The following is a description of a gene set: Human Gene Set: FLETCHER_PBMC_BCG_10W_INFANT_PPD_STIMULATED_VS_UNSTIMULATED_10W_DN species: Homo sapiens Genes down-regulated in peripheral blood mononuclear cell stimulated vs unstimulated in infants (10w) after exposure to BCG (Danish strain BCG Statens Serum Institut, Denmark), time point 10W. Comment: PBMCs drawn at 10 weeks following immunization at birth from publication Fletcher HA, Keyser A, Bowmaker M, Sayles PC, Kaplan G, Hussey G, Hill AV, Hanekom WA (PMID 19239680) BACKGROUND: Novel tuberculosis (TB) vaccines recently tested in humans have been designed to boost immunity induced by the current vaccine, Mycobacterium bovis Bacille Calmette-Guerin (BCG). Because BCG vaccination is used extensively in infants, this population group is likely to be the first in which efficacy trials of new vaccines will be conducted. However, our understanding of the complexity of immunity to BCG in infants is inadequate, making interpretation of vaccine-induced immune responses difficult. METHODS: To better understand BCG-induced immunity, we performed gene expression profiling in five 10-week old infants routinely vaccinated with BCG at birth. RNA was extracted from 12 hour BCG-stimulated or purified protein derivative of tuberculin (PPD)-stimulated PBMC, isolated from neonatal blood collected 10 weeks after vaccination. RNA was hybridised to the Sentrix(R) HumanRef-8 Expression BeadChip (Illumina) to measure expression of > genes. RESULTS: We found that ex vivo stimulation of PBMC with PPD and BCG induced largely similar gene expression profiles, except that BCG induced greater macrophage activation. The peroxisome proliferator-activated receptor (PPAR) signaling pathway, including PPAR-gamma, involved in activation of the alternative, anti-inflammatory macrophage response was down-regulated following stimulation with both antigens. In contrast, up-regulation of genes associated with the classic, pro-inflammatory macrophage response was noted. Further analysis revealed a decrease in the expression of cell adhesion molecules (CAMs), including integrin alpha M (ITGAM), which is known to be important for entry of mycobacteria into the macrophage. Interestingly, more leukocyte genes were down-regulated than up-regulated. CONCLUSION: Our results suggest that a combination of suppressed and up-regulated genes may be key in determining development of protective immunity to TB induced by vaccination with BCG., and this is the list of marker genes: EEF1AKMT3, GPC4, ANXA11, CLIP2, ME1, PTGS1, LHFPL2, ANXA4, LRP3, ASPHD1 (NCBI Gene Id 253982), THEMIS2, EGR2, GSN, CD86, RGCC, TMBIM1, CAPN2, PLXDC2, SMCO4, SCARB2, DCSTAMP, FLVCR2, IGSF6, IL1RN, SLC1A3, SLC17A5, LGALS3, GLIPR2, SLAMF8, LMNA, ICAM5, IL13RA1, SLC27A3, FAM20C, DPYSL2, ANXA1, TNFRSF21, MITF, CD9, ASAH1, IFI30, DAB2, ZNF366, ABCG1, SHTN1, MFSD12, VIM, FABP4, LPL, HK3, VWA5A, SPINT1, ALDH1A2, PI4K2A, CD33, IL1R2, SLCO3A1, HAVCR2, NCEH1, ZMIZ1, CD151, RNASE1, LRP1, S100A4, DHRS9, ENG, TKTL1, SLC38A6, SLC31A2, CA2, S100A10, GLA (NCBI Gene Id 2717), HTRA1, HMOX1, RPS6KA1, APOC1, TSPO, TM4SF19, GLIPR1, VWF, CD36, CTSB, ABCC3, SDCBP, C1orf54, TMT1B, ATP6AP2, SLC44A1, DAGLA, KCNE3, GLMP, HCST, RNF130, CD63 (NCBI Gene Id 967), MYOF, MMP19, INF2, SPHK1, NLRC4, SLC31A1, AIF1, SPRED1, SPP1, FCGRT, FPR3, FLRT2, EMP1, LINC00520, ITGAM, PLBD2 (NCBI Gene Id 196463), SPINK1, PACSIN2, FCN1, STAB1, CYB5R4, CD52, IGF2R, SLC7A8, GCLC, OTOA, GRN, KLF9, LIMS1, FKBP1A, AVPI1, C5AR1, CCR5, NEK6, TGFBI, CST6, MGST1, MRAS (muscle RAS oncogene homolog), MPP1, CORO1C, CSF1R, ATP6V1A, KIAA0930, LYZ, FGL2, PPARG, NRROS, CTSS, CARD9, IGF2BP2, CYFIP1, ALDH3B1, SERPINE1, CCR1, CTSD (cathepsin D), S100A6, SLC1A4, APOE, SLC49A3, LINC01010, SIRPA, PDGFRB, SPRY2, GPNMB, FHL3, FTL, GREM1, HEXB, PLIN2, HSD3B7, CEBPA, PLBD1, RAB34, G6PD, MNDA, ALCAM, NPL, NIBAN2, SDSL, TNS3, PAPSS1, FBP1, RHOC, TIMP2, CAMK1, SLC37A2, CST3